Given this list of marker genes COL16A1, USP7, CLIC5, TLL2, PRMT6 (protein arginine methyltransferase 6), VPS53, CERS3, LDLRAP1, KCNJ6, TRIM35, PAX5, PUM2, COL5A3, NOS1, KCND1, ZNF385A (zinc finger protein 385A), DUSP13A, ST3GAL5, AMOT, DGKK, ZNF862, FAM53A, AGO1, MAP3K11, VPS39, PARP6, KIAA0513, STAB2, MAFG, SLC37A1, FHL1, FNDC3B, NOTCH2, RGMB, GOSR2, SATB1, CACFD1, ANKFY1, TCEA2, DCX, RHBDL1, CHAF1A, TMEM217, C17orf67, GABRA4, ATP2B4, ANKRA2, NQO1, N4BP1, NEUROD4, AIF1L, TRIM26, KCNIP1, RTKN, ERG28, FAM78A, SLC6A17, MORN5, STK35, PPM1M, SMARCD1, RNF19B, KBTBD2, ADAMTS4, CDON, ARHGEF6, SSR1, YTHDF3, SLC10A7, SH3GL2, WDTC1 (WD and tetratricopeptide repeats 1), KIF21B, RASSF4, TRIM4, ETV4, DGKI, PIANP, CECR2, SCML1, RAB1B, SRGAP2, TMEM201, TRIM46, XYLT1, CDIN1, SHOC1, SUSD6, HR, REG3G, NFYA, ACVR2B (activin A receptor type 2B), LUZP1, PRR32, SOX10, STEAP2 (NCBI Gene Id 50630), IKZF1, TENT4A, SDC3, AK3, KLHL14, WASF2, LSM12, KCNB1, HNRNPR, RIMS2, here is a description of the gene set: studied in species Homo sapiens Human Gene Set: MIR6735_5P Genes predicted to be targets of miRBase v22 microRNA hsa-miR-6735-5p in miRDB v6.0 with MirTarget v4 prediction scores > 80 (high confidence targets). from publication Chen Y, Wang X (PMID 31504780)